The following is a description of a gene set: studied in species Homo sapiens Any process that activates or increases the rate or extent of development, the biological process whose specific outcome is the progression of an organism over time from an initial condition (e.g. a zygote, or a young adult) to a later condition (e.g. a multicellular animal or an aged adult). Human Gene Set: GOBP_POSITIVE_REGULATION_OF_DEVELOPMENTAL_PROCESS, and this is the list of marker genes: CAPRIN1, PITHD1, GPER1, SCUBE3, TERT, CAPN2, ETV2, AKT3, PRKDC, NFATC3, MIR34A, GHSR, CXCL9, NSD2, CYP26B1, EMC10, VEGFB, TMEM106B (NCBI Gene Id 54664), JUND, ALOX15B, NOTCH1, CSF1, TSPO, RPTOR, FOXP3, HAX1, DHX37, NEUROD1, CLIC3, SNAI1, ST8SIA2, TWIST1 (NCBI Gene Id 7967), IL17A, MIR29B1, BRAF, IL15, THBS2, PPP1R13L, EHD2, CYB5D2, NEUROD2, PCP4, TNFRSF11A, MEF2C, BTK, SOCS3, LEP, NAP1L1 (NCBI Gene Id 64165), TMEM119, AAMDC, PRKN, NBL1, SFRP4, FRS2 (fibroblast growth factor receptor substrate 2), LINGO4, FLT1, DCSTAMP, MIEF1, CACNG7, CD40, MIR499A, ASXL2, HOPX, ZNF703, ARID2, SCIN, FGF2, RBBP4, NKAP, HMCES, ARMCX5-GPRASP2, ROBO2, MDK, TNFSF13, TIE1, MIR142, PPP3CA, CASP8, DUOXA1, IMPACT, ADGRB1, FAM210B, BRD1, KRT10, DHX36, NIN, FOS, SLITRK4, FAM83A, PRMT5, ETV4, CMA1, MACROH2A2, CSRP3, BMPER, TARBP2, TRPC6, RHOA, BRD7, PF4, SOX15, NEUROG1, FAXDC2, BAX, ITGB2, ZDHHC15, ALK, MIR431, AMOT, CD34, MMP14, XRCC2, IL1A, AGTR1, WARS2, C1QBP, PCK1, CREBL2, TRPV2, BEND6, AKAP6, CXCL12, PDPN, DDR2, SMARCA2, SP7, RASGRP1, CLSTN3, BNIP2, CDX2, KAT5, ARNT, HDAC1, HLA-G, ZBTB7B, HOXB7, MIR486-1, C3AR1, SERP1, LRTM2, HLA-DRB1, MIR130A, MAG, CRB2, CCN1 (cellular communication network factor 1), CX3CR1, MACF1, POU5F1, HIPK1, NGF, PTGS2, XKR8, CDH5, DAB1, BRD9, FZD4, MIR17HG, MAPK12, IL7, ENAM, AGTR2, VWC2, MIR1908, CDON, PLA2G10, ADIPOQ, FGF1, WNT2, PPARGC1B, AMIGO1, SOX6, CCL8, FBXO5, MIR19A, PIEZO1, HLA-DRA, LRRC8A, RNF157, TPH1, BCL6, LPAR3, AR, CCND1, SMARCD2, FOXG1, TNFSF4, ZBTB46 (zinc finger and BTB domain containing 46), CCL19, MIR146A, ACVR1, NF2, MIR208A, CYP27B1, LIMK1, ADIG, DLX2, ING1, BMPR1A, REST, CEACAM1, CCN3, TYROBP, TNFRSF1B, FEZF1, THPO, PACSIN1, RETN, SLC6A6, S1PR2, MYF5, MAPT, RLN2, RAPGEF3, PLD6, FGF10, RXRB, RAG1, GLI3, DDHD2, MFF (mitochondrial fission factor), RBPJ (recombination signal binding protein for immunoglobulin kappa J region), FOXN1, PLAAT4, BCL11A (BCL11 transcription factor A), TGFBR2, BTN2A2, BRMS1, EMP2, PLXND1, IL7R, SPHK1, PTPRZ1, HEY2, MIR19B1, ADM2, POR, CUX2, ELL3 (elongation factor for RNA polymerase II 3), TLR3, AHI1, TCF15, RNF112, ERAP1, MIRLET7B, RALA, BMAL1, NLGN2, MIR30A, C21orf91, CD74, POU3F2, GOLGA4 (golgin A4), NFKB1, MIR22, BRMS1L, GDPD5, RIN2, LRP5, NCOA3, LIF, LILRB2, HSPA1B, SOD2, DRD2, SPEN, NTRK3, RANBP3L, SNAI2, RHOB, SOX10, ARHGEF7, GCNT2, MMD2 (monocyte to macrophage differentiation associated 2), TAL1, ITPKB, MTCH2, RHEX, CAPN3, ZNF304 (zinc finger protein 304), BMPR1B, FLRT1, HSPB6, NOTCH4, WNT4, SLITRK2, S100B, AMIGO3, HK2, MECP2, WIF1, NACA, VSIR, TBC1D24, LIN28A, IFITM1, COL1A1, INSM1, MDM2, TCF12, FOXJ1, CLIC1, IL10, DLL1, F3, OBSL1, TP63, RBM4, SEMA4A, ACVRL1, ADRB2, HTR2C, CTHRC1, SOX11, OCSTAMP, FBXW8, NGFR, LAMA1, MAMSTR, NPPC, CAMP, TBXA2R, DNAI3, KCTD11, STK3, EGR2, APP, NR6A1, GSK3B, IL1RL2, HTR2A, RARRES2, IL12B, RHEB, ANO6, RUNX1, TMIGD2, DSG2, NFKBID, TLE6, HSPB1, WNT7B, CLSTN1, DPF2, LIG4, TNN, CD4, CPNE6, MIEF2, TRPC5, SLC9B2, ITGB3, SYT2 (NCBI Gene Id 6858), PLXNB3, NCOA1, RET, PTN, DLX1, CXCR3, HTN1, NAPEPLD, RASAL1, SMURF2, GLIPR2, RBBP7, TBX5, SYDE1, LAMC1, IGF1 (NCBI Gene Id 3479), LYN, RGCC, FFAR4, RALBP1, BCL7A, SHB, ZBED2, DNM1L, LRRTM3, SUDS3, RAC1, C3, LRRC24, ZFHX3, DSCAM, WNT10B, FOXO3, SHLD2, SOX9, SYT3, MCU, DAG1, SEMA5A, ACACB, PPARG, FGFR2, SRY, SPAG9, NRP1, EDN3, IL1RAP, TM4SF19, KLF4, PAK4, IL4R, SMO, VDR, GDF7, SLIT2, HDAC6, PEX5, KDM2B, S100A1, BCL9L (NCBI Gene Id 283149), BTC, APLNR, OVOL2, ANKRD27, PARP1, ACTL6A, TFAP2A, TNFSF14 (TNF superfamily member 14), TBX2, APOE, SPDEF, GHRHR, IL18, PARP2, CBLN2, NRDC, TIAM2, CX3CL1, HPSE, SOX12, JAK2, TGFB3, WNT1, DVL2, TRIM16, CD24 (NCBI Gene Id 934), PTPRC, CLCF1, MIR137, SFN, SMARCD1 (NCBI Gene Id 6602), CDKL3, HMGB2, CLCN2, SLITRK1, KMT5C, ESRRB, RELA, RACK1, ENPP2, ATXN1, MIR222, MACROH2A1, CDK1, SMARCD3, AURKA, BAD, CDH4, LGALS3, DVL1, CLSTN2, ECT2, FGF20, GDF3, SERPINB3, CCL11, LPL, VNN1, CD86, RB1, MIR31, GHRH, PTPRD, ABCB10, MIR204, ZNF268, TCF7L2, MIR451A, HLX, ATAD5, ZBED3, CUL7, LNCPRESS1, SOX13, CD53, BLOC1S5, ACVR2A, BTG1, SS18L1, MIR1-1, MAPK6, GLUL, PDCD6, CCN5, SLC6A3, GPR21, OGT, PGAM5, PDE3A, INSR, SMYD1, PTGIS, FZD3, ASB4, AQP1, ERBB3 (NCBI Gene Id 619500), OLIG2, MYOG (myogenin), CCL24, CD36, BASP1, OTP, UNC5C, STAU2, TEK, BOC, ANGPTL4, WNK1, SRF, OPA1, TBX21, EFNB2 (NCBI Gene Id 1948), WNT3, NCKAP1L, MCUB, NRG1, RAG2, PTK2B, HNRNPU, DISC1 (DISC1 scaffold protein), CUX1, ECM1, TESC, DPF1, MYLK3, PLAA, MAGED1, RHOH (NCBI Gene Id 399), KRT17, MIR511, FES (FES proto-oncogene, tyrosine kinase), NPNT, ARID1B, HMOX1, LAMB2, LRG1, MYDGF, BDNF (brain derived neurotrophic factor), SRC, MIR140, VEZF1, MESP1, GPAM, AGGF1, SOX2, ADGRB3, SYT14P1, SYNDIG1, PCID2, CAMK1, SHLD1, BNIP3, CACNA2D2, IL6ST, CHRNA7, RIF1, PRL, CHD7, NR2C2 (NCBI Gene Id 7182), FGF18, SULT1E1, MIR548C, EPHA1, ITGB8 (integrin subunit beta 8), ITSN2, LINGO2, FGFR1, NEUROG3, WWTR1, PLXNC1, IQGAP3, ZDHHC6, ZNF322, CD28, FADD, BMP2, STK4, GATA3, DAB2, MIR199B, RELN, MRTFB (myocardin related transcription factor B), NLGN3, MARCHF5, FAM20C, SCARF1 (NCBI Gene Id 8578), UPF3B, PRKCZ, HSPA1A, VSTM2A, SRPX2, ADAM12, SERPINE1, CR1, AMBRA1, ZC3H12A, FOXA1, ILK, LRRTM2, OXT, SEMA4D, GPRASP3, MAP2K2 (NCBI Gene Id 85511), NOS3, SAP130, NRCAM, LGALS1, LRP2, CCDC3, ADAMTS9, KAT7, SOCS5 (NCBI Gene Id 9655), HGF (NCBI Gene Id 317720), MIR17 (NCBI Gene Id 406952), CAV3, TJP1, MIR132, PLA2G2A, P2RX7, TP53BP1, WDR62, HSF1, RIPOR2, MIR1224, ADM, VASH2, NOTCH2, BIN1, CEBPD, LMO3, TESPA1, RIPK1, NR5A1, VWC2L (NCBI Gene Id 402117), METRN, PROX1, GDPD2, NINJ1, FN1, PRKG2, CLDN5, PIK3R6, SERPINF1, ING2, SMARCE1, AP3D1, PRKAA1, ACIN1, VEGFC, ZBTB7C, AXL, VSTM5, FOXA2, FOXS1, MIRLET7G, FNDC5, RASSF10, TMEM100, ZNF365, POU4F1, NOG, HES1, MIR519D, INPP5D, PRMT1, DCN, SERPINF2, LCK (NCBI Gene Id 95387), EFNA5, MYOCD, PPIB, FZD1, CREB1, ADIRF, MIR30B, MLH1 (mutL homolog 1), SYT1, CBLN1, PRKCB, TET1, FZD9, PINK1 (NCBI Gene Id 65018), MTM1, MIR181A2, CFL1, KLF10, CCR1, HOXA5, ZEB1, CCN6, CCBE1, SH3GL3, ALOX5, TRAF6, TGFBR1, CEBPA, CXCL8, MAN2A1, FGF8, MSR1, SLC20A2, SP1, STAT3, TNFRSF1A, F11R, EPHB2, ANGPT2, RBM24, EIF4G1, IL20, PUM2, GREM1, TMEM79, PKM, ASIC2, ITSN1, NEFL (neurofilament light chain), SS18, TNXB, NR5A2, MEDAG, CPNE5, VLDLR, PLCG1, EXOSC6, SSBP3, TREM2, SART1, SRRT, MIR27B, PAFAH1B1, GDF2, MIR143, NID1, NKX6-1, SHANK1 (SH3 and multiple ankyrin repeat domains 1), EEIG1 (NCBI Gene Id 90676), PRKD1, MTDH, SORL1, PAK1, IL21, SLC8A1, GPR65, NLRP5, ZFP36L1, IL15RA, LEF1, DBN1, OSR2, CDKL5, IL34, MME, FOXC2, SCX, CD27, UNC13A, TGFB1, HOXB4, KL, MAD2L2 (mitotic arrest deficient 2 like 2), HYAL1, TGFB2, PTCH1, AGT, IRX3, CCNB1, SMAD5, TENT5A, EZH2, PA2G4, ADCY10, CORO1B, RXRA, PLA2G5, BBS2, SIX1, RCOR1, RAPGEF2, LAMB1, MIR342, SOX4, MIR125B1, SMAD3, CXCR4, AGO2, STOX1, TNFSF12, VIL1, PNP, DCT, STK25, CCN2, GDI1, TMEM64, MAP3K13, ANGPT4, TCF3, TRIM32, PHOX2B, CTNNB1, MPL, LPAR1, E2F1, IL23R, KAT2A, SMARCA4, MIR214, BMP7, OPRM1, TACSTD2, GDF10, RAB7B, ATP2B1, SIRT1, PAX2, ITGA5, BICRAL, ISL1, IL1RAPL1, RND2, PRKCH, TGFBR3, HIPK2 (NCBI Gene Id 653052), IST1, EPHB3, MIR145, NIPBL, LBH, SYAP1, MIR92A1, IL5, TTBK1, MIR548D1, TNFSF11, LILRB4, PIM1, GPC1, ANKRD54, FOXO6, INHBA, CDC20, DKKL1, SASH1 (NCBI Gene Id 387570), DMRT1, MEGF8, PMS2, RARA, MAPK11, CTH, GLI2, SETD3, ATP11A, COBL, CBFB, ADRA2C, SIRT6, SPIRE1, MED1, MSX1, LGALS9, NR1H4, SHLD3, TFRC, ACVR2B, EGF, SHH, PLXNB2, IL6, ELAPOR2, PSEN1, FLOT1, MIR200C, CARM1 (NCBI Gene Id 10498), LLPH, ADD1, IL4I1, MIR221, CYLD, CTNNBIP1, YAP1, NFATC2, CAPRIN2, CD46, FXR1, SEMA7A, SPRY1, TNFSF13B, PDPK1, SIN3A, APELA, CMKLR1, MIR424, NLRP3 (NLR family pyrin domain containing 3), DLG5, TNFRSF12A, STAT5B, TGM2 (transglutaminase 2), TRAK1, SULT2B1, GCM1, WNT2B, AKT1, DDRGK1, PROM1, PDGFB, RBM19, EGR3, BRD2 (bromodomain containing 2), EXOSC3, WNT5B, RIMS2, FEZF2, ZNF335, SIX4, SMURF1, GRN, RAMP2, SOX5, MIR29A, TP73, TBX20, NUDT21, MIR27A, CRABP2, HAP1, MIR18A, ZNF488, SMAD2, MIR206, SASH3, MYB, TRADD, STAT5A, FST, ZNHIT1, MAP6, MYC, SYCE3, MIR199A1, BMP6, ADNP, KDM5B (lysine demethylase 5B), ZBTB1, PLCB1, ASCL1, CD83, BRINP2, RUNX2, PRKCA, NEDD4L, RIPK2 (NCBI Gene Id 8767), DDAH1, NPTN, TOX, PAX8, FUT1, TGIF2, GHR, ROBO1, LHX1, TAPT1, HMG20B, BRINP1, ADA, PRKCI (NCBI Gene Id 5584), SLC4A2, IL36B, MIR106A, CITED2, MIR21, NUMB, RRAS, LMOD3, LRRN1, GRID2, PARP6, BMP10, MIR20B, SERPINE2, MIR150, ADAM9, IGF2, GSX2, INS, SMOC2, RFX3 (regulatory factor X3), FLRT3, ACTL6B, BCL7B, TGFB1I1, HCLS1, ZMYND8, CLEC7A, CYP1B1, ENG, HOXD3 (NCBI Gene Id 3232), BICRA, AXIN2, MUSTN1, GAL, DMRTA2, MIR210, KLHL25, NTN1, SOCS1, ZFP36, RTN4, ARID1A, ATOH1, NCOA2, MSH2, NAP1L2, LRRC4B (leucine rich repeat containing 4B), ZNF219, NEDD9 (neural precursor cell expressed, developmentally down-regulated 9), HDAC2, ACTB, ARX, MKKS, BMP1, EMILIN1, FGF9, ETV5, QKI, MSTO1, PML, APOB, FRZB, CDKN2A, NUMBL, ID4, MUL1, PBRM1, AGR2, PRMT3, SLC23A2, DAB2IP, AP3B1, IHH, MIR181B1 (NCBI Gene Id 406955), ZEB2, PTK2, HSP90AB1, ETS1, CCR3, ARID4B, SCGB3A1, GRM5, PPARD, EPHA4, PWP1, NFE2L2, RUFY3, GATA5, NLGN1, EVI2B, ABL1, MIR185, MIR99B, KIT, BMP5, GHRL, SKIL, GPRC5B, EEF2K, ZC4H2, GLI1, PKP1, TBX1, XRCC5, NR2E1, L1CAM, PLAG1, EPHB1, PRKD2, PIAS1, LRP8, WNT5A (Wnt family member 5A), SMAP1, NRXN1, GH1, AMTN, STAT1, ARID4A, MYOD1, CDS1, OSR1, SMARCB1, TCF4, VHL, LGR4, IL6R, GAB1, PIK3CD, SUCO, TAOK3, IFNG, ITGB1, DDHD1, ADGRV1, KLF5, LOXL2, KITLG, PLXNB1, ANXA3, MAPK9, ALX1, RPS6KA1, SPI1, CFTR (NCBI Gene Id 1080), AMIGO2, MIR20A, ID2, LTBP3, PPP2R3C, SLITRK5, B4GALT5, MAP3K5, SOCS2, TNF (NCBI Gene Id 7124), SAP30L, WNT3A, CD101, TGIF1, SINHCAF, TRIB1, TENM4, SAV1, TMPRSS12, SYT17, SYK, XRCC6, UTP25, MAP2K1, SMARCC2, SFRP1, EMILIN2, FOXD1, PKDCC, RUNX3, NODAL, GDNF, MMRN2, ZBTB16, MIR133A1 (microRNA 133a-1), TIAM1 (NCBI Gene Id 7074), LRRTM1, C5AR1, TWF2 (NCBI Gene Id 11344), LAMA2 (laminin subunit alpha 2), YME1L1, ZHX3, SMAD7, NOCT, HMGB1, AGER, NEURL1, IGFBP3, KMT5B, TLR9, LTF, FBN2, MIR126, ARRB2, MIR590, MALT1, PROC (protein C, inactivator of coagulation factors Va and VIIIa), MTURN, NUMA1, MYRF, JCAD, MYF6, ITGAX, LBX2, PAX6, IQSEC2 (IQ motif and Sec7 domain ArfGEF 2), ANXA1, SLITRK6, FERMT2, KRT2, XBP1, BMPR2, ADAMTS20, EP300, EZR, RAB21, ITPKA, NKX6-2, BBS4, DMD, SDCBP, VPS35, ARHGEF2 (Rho/Rac guanine nucleotide exchange factor 2), NELL1, WDFY2, JAG1, GDF6, ACTN3, TPBG, CSF3, SIRT2, DVL3, IL2, SPINT1, SHANK3, TRPM4, ZFYVE27, GATA4, NKX2-5, BRD4, CYBB, SMARCC1, ISLR2, ZNF16, IL2RA, MIR378A, HOXA11, NEUROD4, ADAM7, IL2RG, SPRR5, JAK1, WT1, IL4, MAML1, KHDC3L (KH domain containing 3 like, subcortical maternal complex member), IL23A, MIR509-1, MSX2, BCL7C, SNW1, CD80, CAMK2B, MIR9-1, RGS14, EPO, MIR125A, NKX2-2, BAIAP2, FOXC1 (NCBI Gene Id 3666), ERBB4, MAPKAPK5, CEBPB, JMJD8 (jumonji domain containing 8), LRP3, OLFM1, MTOR, ANAPC2, NTRK1, NTRK2, ODAPH, ZNF385A, PAXIP1, STK11, TFE3, BMP4, CORO1C, KDF1, KDR, CALCA, JUP, GJA1, UFL1, MICOS10-NBL1, OTX2, DLG4, WNT7A, PTCH2, PPP1CC, TNFSF9, JUNB, HEYL, BRCA1, GPR68, ATRAID, YBX3, EFEMP2, GPM6B (NCBI Gene Id 2824), FIS1 (fission, mitochondrial 1), KDM1A, BLOC1S6, GDF15 (NCBI Gene Id 9518), GRIP1, GATA2, LCN2, FXR2, METRNL, SYT4 (synaptotagmin 4), AGRN, BCL2, SPTBN4, SHOX2, HIF1AN, DICER1, HIF1A, CSF2, LTA, GATA6, WNT6, GATA1, ADAM8, DMRT2, RPS6KA3, DUSP10, SFRP2, RIMS1, ASPM, MAPK14, HMGA2, CPNE9, DIO3, ANGPTL3, ATOH8, MIR133B, IL13, MIXL1, CCN4, DKK1, SOX17, CHI3L1, ZAP70, CNTF, FMR1, SLITRK3, KRAS, SMAD4, SMAD1, ADGRB2, ZMIZ1, SHOC2, IL12RB1, PLS1, AMELX, IPO7, MMD, SAP30, BAMBI, SHTN1, ISG15, NFKBIZ, SLC30A1 (solute carrier family 30 member 1), HOXC11, VEGFA, STIM1, AKIRIN1, SLC7A5, NME2 (NME/NM23 nucleoside diphosphate kinase 2), PHF10, MAP1B, BNC1, KAT8, GFAP, EDN1, PRDM14, ATP8A2, FLRT2, GAS6, ZP3, RAP1A, PDCL3, ACVR1B, STAT6, SOX8, EHD1, GDF5, ABCB1, MIR3648-1, CELA1, CPNE1, IRGM, CHODL, IL1B, RREB1, THBS1, LRRN3, POU4F2, PLA2G3, ZFPM2, ADRA2B, TEAD4, DPF3, BRINP3, ATF4, CPEB3, PTH, OLFM2